Given this list of marker genes Actb, Ss18l1, Actl6a, Smarce1, Ss18, Arid1a, Bcl7c, Dpf3, Smarcb1, Smarcc1, Bcl7a, Smarca4, Bcl7b (NCBI Gene Id 12054), Smarcd1, here is a description of the gene set: Mouse Gene Set: REACTOME_FORMATION_OF_THE_CANONICAL_BAF_CBAF_COMPLEX Formation of the canonical BAF (cBAF) complex studied in species Mus musculus